The following is a description of a gene set: Genes down-regulated in mammary glands from the CITED1 knockout mice: homozygotic vs wild type (WT) animals. Expression microarray analysis identified CITED1 among a group of genes specifically upregulated in the pubertal mouse mammary gland. At puberty, CITED1 localizes to the luminal epithelial cell population of the mammary ducts and the body cells of the terminal end buds. Generation of CITED1 gene knockout mice showed that homozygous null mutants exhibit retarded mammary ductal growth at puberty and, in addition, dilated ductal structures with a lack of spatial restriction of the subtending branches. Analysis of CITED1 homozygous null and heterozygous null mammary gland gene expression using microarrays suggested that the mammary-specific phenotype seen in the homozygous null females is due to a disturbance in the transcription of a number of key mediators of pubertal ductal morphogenesis. These include estrogen and TGFbeta responsive genes, such as the EGFR/ErbB2 ligand, amphiregulin, whose transcription we suggest is directly or indirectly regulated by CITED1. from publication Howlin J, McBryan J, Napoletano S, Lambe T, McArdle E, Shioda T, Martin F (PMID 16278680) Human Gene Set: HOWLIN_CITED1_TARGETS_2_DN studied in species Mus musculus, and this is the list of marker genes: BPGM, GALC, TRIM34, CHRDL1, MPZL2, TMEM45B, SLC41A2, PHGDH, FGG, STC2, VAMP3, BID, AMACR, CAVIN3, SORL1, CITED1